Given this list of marker genes Hspa1b, Hspa1a (NCBI Gene Id 193740), Klf2, Ubc, Rhob, Cxcr4, here is a description of the gene set: from publication Cui A, Huang T, Li S, Ma A, Pérez JL, Sander C, Keskin DB, Wu CJ, Fraenkel E, Hacohen N (PMID 38057668) Genes negatively differentially expressed in cell type: γδ T cell upon treatment with cytokine: RANKL in mouse lymph nodes in vivo. Mouse Gene Set: CUI_T_CELL_GD_RANKL_RESPONSE_DN Cytokines mediate cell-cell communication in the immune system and represent important therapeutic targets. A myriad of studies have highlighted their central role in immune function, yet we lack a global view of the cellular responses of each immune cell type to each cytokine. To address this gap, the authors created the Immune Dictionary, a compendium of single-cell transcriptomic profiles of more than 17 immune cell types in response to each of 86 cytokines (>1,400 cytokine-cell type combinations) in mouse lymph nodes in vivo. A cytokine-centric view of the dictionary revealed that most cytokines induce highly cell-type-specific responses. For example, the inflammatory cytokine interleukin-1β induces distinct gene programmes in almost every cell type. A cell-type-centric view of the dictionary identified more than 66 cytokine-driven cellular polarization states across immune cell types, including previously uncharacterized states such as an interleukin-18-induced polyfunctional natural killer cell state. species: Mus musculus